The following is a description of a gene set: species: Homo sapiens Human Gene Set: GOBP_SPHINGOID_METABOLIC_PROCESS The chemical reactions and pathways involving sphingoids, any of a class of compounds comprising sphinganine and its homologues and stereoisomers, and derivatives of these compounds., and this is the list of marker genes: PLPP3, ACER2, ASAH2, SPTLC1 (serine palmitoyltransferase long chain base subunit 1), SPTLC3, ACER1, ABCA2, ACER3, SPTSSB, AGK, GBA1, NAAA, SPTSSA, ASAH1, SPTLC2, DEGS2, SPHK2, SGPP2, PLPP2, PLPP1, KDSR, SGPP1, SPHK1